The following is a description of a gene set: Mouse Gene Set: GOBP_RESPONSE_TO_ENDOTHELIN Any process that results in a change in state or activity of a cell or an organism (in terms of movement, secretion, enzyme production, gene expression, etc.) as a result of an endothelin stimulus. Endothelin is any of three secretory vasoconstrictive peptides (endothelin-1, -2, -3). species: Mus musculus, and this is the list of marker genes: Ednrb, Sirt6, Kdm6a, Crk, Bcar1, Shc1, Prkd1